Given this list of marker genes DOCK2, RAB11A, CBL, GNB1, ARRB1, PDPK1, CXCR2, GNAI2, PPP2CA, ARRB2, PRKCB, FGR, CXCL8, DNM1, PIK3R6, AKT1 (NCBI Gene Id 207), PLD2, PLCB2, GNA15, PLCB3, RAC2, GNA14, PLCB1, PRKCG, PPP2R1A, ELMO1, RAB7A, PRKCA, LYN, RAB5A, HCK, VASP (NCBI Gene Id 7408), GNG2, PIK3CG, here is a description of the gene set: studied in species Homo sapiens Human Gene Set: PID_IL8_CXCR2_PATHWAY IL8- and CXCR2-mediated signaling events from publication Schaefer CF, Anthony K, Krupa S, Buchoff J, Day M, Hannay T, Buetow KH (PMID 18832364)